Given this list of marker genes PMS2, MLH1, here is a description of the gene set: Reactome Pathway: Defective Mismatch Repair Associated With MLH1 The MLH1:PMS2 complex is homologous to the E. coli MutL gene and is involved in DNA mismatch repair. Heterozygous mutations in the MLH1 gene result in hereditary nonpolyposis colorectal cancer-2. species: Homo sapiens part of: Diseases of Mismatch Repair (MMR)